The following is a description of a gene set: studied in species Mus musculus Mouse Gene Set: MIR_466A_3P_MIR_466D_3P_MIR_466E_3P Genes predicted to be targets of miRBase v22 microRNA mmu_miR_466a_3p, mmu_miR_466d_3p, mmu_miR_466e_3p in miRDB v6.0 with MirTarget v4 prediction scores > 80 (high confidence targets). from publication Chen Y, Wang X (PMID 31504780), and this is the list of marker genes: Cul3, Gabra2, Fech, Trpc1, Slc5a3, Aurka (NCBI Gene Id 99385), Golt1a, Ptp4a3, Grsf1, Cd209a, Fchsd2, Pum2, Prr12, Mstn, Arl6ip6, Sim1, Pter, Slc30a1, Runx2, Grem2, Sav1, Serpinb9g, Pias1, Ralgapa1, Cttnbp2, Zfp397, Ints6l, Fsd1l, Pdik1l, Trim59, Oas3, Lcorl, Anks1b, Lamtor3, Scn2a, Pea15a, Usp1, Med14, Dusp10, Akain1, Rnf38, Cflar, Glipr1l2, Kcna2, Rhobtb1, Arhgef7, Gm11992, Zfp143, Rerg, Car5b, Tmem196, Itch, Epb41l2, Mapk1, Kif13a, Txlnb, Nectin4, Osbpl8, Zfand5, Cbln1, Fhip1b, Nup93, Mcu, Tnfrsf11b, Xiap (NCBI Gene Id 74774), Slc1a1, Zfp27, Pgm2l1, Cyth3, Rai1, Btf3l4, Ndrg4, Mllt3, Gpatch8, Sp4, Ets1, Cldn34c1, Grm5, Rnf138, Adgrf5, Zbtb49, Pcsk5, Cspp1, Ttc7, Fzd8, Mei4, Gramd1c, Tbx22 (NCBI Gene Id 320762), Tet3, Cdh2 (NCBI Gene Id 12558), Cysltr1, Spty2d1, Qtrt2, Schip1, Tmf1, Frmd6, Yaf2, Hoxd1, Xkr6, Mdm1, Tlr3, Fignl1, Ikbkg, St8sia4, Wiz, Golim4, Slc4a7, Smad9, Atad1, Fam76b, Camsap2, Pafah1b1, Wrnip1, Topbp1, Bmp5, Pfkfb2, Lin52, Lrch2 (leucine-rich repeats and calponin homology (CH) domain containing 2), Krt73, Psma3 (NCBI Gene Id 19167), Itgb1, Il1rap, Hopx, Irf2bpl (interferon regulatory factor 2 binding protein-like), Zmym5, Chrna1, Prpf4b, Emc7, Mrpl39, Ddx10, Fgd4, Rev1 (REV1, DNA directed polymerase), Calca, Ednra, Zfand2a (NCBI Gene Id 231825), Bmper, Arl8a, Snx27, Tmprss5, Avl9, Kcnma1, Cdkn2aipnl, Qrich1, Wdr43, Pmp22, Bmpr2, Tmc8, Luc7l2 (NCBI Gene Id 75005), Grk6 (G protein-coupled receptor kinase 6), Plag1, Dapk1, Sirt1, Sclt1, Tulp4, Arap2, Prkcd, Slc38a2, Piezo2, Psd3, Rad21, Epc2, Zmat1, Dleu7, Jph1, Zfp446, Hectd2, Tbc1d22b, A630023A22Rik, Appl1, Hnrnpll, Lrp8, Ttll7, Mfhas1, Abcg3, Nek1, Mospd2, Serpinb9d, Nxpe3, Ell2, Mast4, Tpm1, Vamp1, Gje1, Cfap20, Evx2, Cadm1, Svil, Bche, Mkln1, Mthfd1 (methylenetetrahydrofolate dehydrogenase (NADP+ dependent), methenyltetrahydrofolate cyclohydrolase, formyltetrahydrofolate synthase), Myt1l, Rad51d, Ulk2, Btaf1, Cep126, Zc2hc1a, Gm5114, Zfp354c, Rnf111, Prrx2, Kbtbd3, Far1, Cacna1g, Lix1l, Gtpbp2, Usp6nl, Rtp1, Dennd4a, Dck, Kcns2, Gopc, Tcf12, Maco1, Irs1, Pik3c2a, Slc18a2, Fam228b, Rnf144a, Grhl3, Ctdspl2, Nr3c2, Zfp592, Sart3 (squamous cell carcinoma antigen recognized by T cells 3), Kcnh8, Mtmr12, Klf15, Ankrd13c, Fut9, Reps2, Smad1, Lifr, Slc8a1, Neurod6, Mkrn2os, Zfp874b, Phrf1, Ctsc, Zfp407, Asah1 (NCBI Gene Id 67617), Rsbn1, Sgms1, Gfod1, Pms1, Pdcd10, Casz1, Ccnc, Vmn1r51, Cep135, Rps6ka3, Rbm24, Tnrc6c, Mbd2, Cobll1, Adgre4, Sumf2, Crebrf, Dcun1d3, Traf3ip1, Fam118b, Nfkbia (NCBI Gene Id 18035), Iars2, Mbnl1, Gnaq, Zc3h12c, Mzt1, Nr2c2, Mex3b (NCBI Gene Id 93845), Fgfr2, Ptprr, Hace1, Mrc1, Mpc1, Akap12, Zfp781b, Akr1c20, Ube3a, Cxxc4, 1700028K03Rik, Zfp521, Lypd1, Yes1, Rbbp5, Sema3a, Rock2, Vegfa, Rbm41, Diaph2, Gm6377, Tjp2, Shoc2, Sft2d3, Kdm6a, Nfyb, Rb1cc1, Gm5592, Fam8a1, Nfatc1, Ccdc166, Reck, Dip2b, Spred1, Prkacb, Hhip, Cenpi, Dcun1d4, Rgmb, Abi1, Scamp2, Slco2b1, Dcdc2a, Itga2, Ube2a, Scoc, Rnf44, Chrdl1, Glrb, AI182371, Hivep1, Atosa, Tafa1, Cnbp, B3galt2, Satb2, Car8, Matn2, Cask, Atp2b4, Mid2, Rcn2, Setd2, Cnih4, Gata3, Strbp, Lats1, Fbh1, Lin54, Tceanc, Ier3, Sema4b, Ino80d, Cdk6, Tm9sf3, Wt1, Wrap73, Mex3c, Lrrn1, Hs3st3b1, Pax9, Carf, Csrnp3, Slitrk4, Arhgap35, Ppm1h, Sf3a1, Cdc42se2, A830018L16Rik, Glis3, Hoxb3, Fbxo33, Extl2, Kcne4, Rif1, Alg6, Rbm39, Riok3, Secisbp2l, Adra1b, Pak2, Csn2, Mtmr6, Hnrnpa3, Lrig3, Ccdc169, Trhr, Herc6, Plxna2, Dennd2b, Uty, Fbxl17, Camk2d, Six6, Zfp608, Igfbp1, Dst, Ddx60, B3galt1, Nrf1, Gucy1b1, Rab14, Morc3, Cd53, Znrf3, Slc7a2, Crybg3, Nodal, Matcap1, Pik3r1, Pou2f1, Ythdc2, Marchf6, Omg, Polr3d, Epha4, 1110059G10Rik, Cadm2, Gucy1a2, Rab39, Dph6, Slc5a8, Sbf2, Vps26a, Ptpn4, Zswim6, Eif4ebp1, Pip4k2c, Des, Nom1, Cdc14a, Klhl14, Trdmt1, Slc6a6, Ppp1r9b, Heatr5b, Smu1, Ccdc68, Arfgef2, Akap7, Dlx4, Cstf3, Necab1, Ric1, Rab11fip3, Tob2, Dlg2, Dbx1, Nectin3, Tshz3, Clcn2, Ssbp2, Slc12a6, Il21, Rabgap1l, Etaa1, Arhgap6, Golph3, Rnf214, Dmxl1, Cxcl5, Pkd2, Wdfy3, Nhlh1, Cmtr2 (cap methyltransferase 2), Rc3h2, Zbtb2, Eml6, Ctdsp1, Mkrn3, Nceh1, Srsf2, Slc7a11, Ms4a4c, Akap13, Gpm6b, Nck2, Taok1, Phactr2 (phosphatase and actin regulator 2), Or52n4, Tmem151a, Cacnb2, Tada1, Rusc2, Stxbp5, Necap1, Timm8a1, Dync1li2, Ppat, Styx, Pi15, Tle4, Usf3, Mat2b, Gm4884, Tgfbr3, Zfp36l1, Skint9, Loxl3, Anln, Fosb, Cwc22, Fgf4, Tagln2, Mis18a, Neurod1, Filip1l, Ptprb, Col23a1, Il1b, Vps35, Tbc1d24, Lrp12, Mpzl1, Baz2b, Itpr1, Cxcl1, Il3, Zbtb44, Acsl4, Tubgcp5, Naa20, Pira12, Rmnd5a, Chuk, Ewsr1, Nup35, Zbtb10, Adamts1, Gtf2b, Adamts20, Lhx8, Zc3h4, Phf6, Dnajb12, Aspm, Rasef (NCBI Gene Id 242505), Lss, Arhgef10l, Erich1, Gabra1 (NCBI Gene Id 14394), Cenpc1, Dach2, Hnrnpd, Cks2, Apool, Apobec3, Pfkfb3, Zdhhc21, Tnfaip8, Phactr4, Ubqln2, Irf1, Orc1, Krit1, Chek2, Epb41l1, Smad7, Syncrip, Rufy2, Unk, Zfp148, Zfp689 (NCBI Gene Id 71131), Wdr47, Spock3, Fgf12 (NCBI Gene Id 320320), Megf11, Fgl2, Nup155, Spry1, Zmym2, Cxcl16, Dnttip2, Iqschfp, Pcf11, Rictor (NCBI Gene Id 78757), Ano4, Stard13, Bpnt2, Pbrm1, Dkk3, Grip1, Otud6b, Homer1, Skint7, Mef2a (NCBI Gene Id 320979), Lrrc42, Hook3, Wnt3, Utp18 (NCBI Gene Id 76152), Zfp266, Tmtc4, Foxf2, Kif23, Lemd3, Taf4b (TATA-box binding protein associated factor 4b), Kif16b, Mdp1, Sorcs3, Epha5, Ncam2, Rgs4, Gabpa, Aff4, Klhdc2, Tfg, Ttc38, Ap1g1, Ankrd1, Spag9, Mfsd2a, Tab2, Slc16a10, Ash1l, Msx2, Trhde, Rreb1, Vcan, Carmil1